Given this list of marker genes Casp3, Casp4, Gsdmd, here is a description of the gene set: part of: Innate Immune System studied in species Mus musculus Reactome Pathway: Non-canonical inflammasome activation electronically inferred by orthology from the curated human pathway This event has been computationally inferred from an event that has been demonstrated in another species.<p>The inference is based on the homology mapping from PANTHER. Briefly, reactions for which all involved PhysicalEntities (in input, output and catalyst) have a mapped orthologue/paralogue (for complexes at least 75% of components must have a mapping) are inferred to the other species.